Given this list of marker genes Ndc80, Tuba3a, Plk4, Ppp2r5d, Tubb4b, Ppp2r5e (protein phosphatase 2, regulatory subunit B', epsilon), Tuba1b, Ppp2r5a, Clip1, Cenpt, Smc4, Cep41, Csnk2a1, Hsp90aa1, Stag1, Kif2c, Ppp2r1a, Tubg2, Cdca5, Tuba4a, Nedd1, Csnk2b (casein kinase 2, beta polypeptide), Cdca8, Ccnb1, Cenpc1, Tubb6, Pds5b, Tubgcp2, Ska2, Itgb3bp, Nek2, Stag2, Mapre1, Pds5a, Cep70, Kntc1, Tuba8, Cenpl, Tubal3, Cep192, Bub1b (BUB1B, mitotic checkpoint serine/threonine kinase), Cenpf, Cenpo, Cep43, Tubb2b (NCBI Gene Id 73710), Seh1l, Bub1, Smc3, Ssna1 (NCBI Gene Id 98824), Sgo2a, Ppp2ca, Xpo1, Cep152, Wapl, Ckap5, Nup133, Cetn2, Rps27, Cenpq, Ofd1, Ska1, Cep250, Rad21, Mis12, Ahctf1, Tubb2a, Tubg1, Kif2a, Mzt1, Aurkb, Tuba1a, Dync1i1, Dctn2, Dync1li2, Pcm1, Zwint, Mad1l1, Dynll2, Zwilch, Ncapd2, Tuba3b, Cenpe, Akap9, Cenps, Tubgcp4, Cenpa, Rps27rt, Odf2, Bub3, Dctn3, Clasp2, Smc1a (NCBI Gene Id 80490), Spdl1, Taok1, Nuf2, Ppp2cb, Prkaca, Csnk1d, Haus5, Cdk1, Ninl, Firrm, Cenpk, Alms1, Smc2, Nup37, Tubb4a, Dync1h1 (dynein cytoplasmic 1 heavy chain 1), Haus8, Nup107, Eml4, Nup43 (nucleoporin 43), Cenpm, Cenpu, Ndel1, Zw10, Sdccag8, Spc25, Actr1a, Nde1, Kif2b, Nup98 (NCBI Gene Id 330609), Cdc20, Ppp1cc, Cenpn (centromere protein N), Cep164, Ywhae, Tubgcp5, Tubgcp6, Ppp2r1b, Mad2l1, Nudc, Tubgcp3, Haus4, Cep72, Csnk2a2, Haus1, Ppp2r5c, Tubb3, Cep63 (centrosomal protein 63), Nsl1, Incenp (NCBI Gene Id 98139), Ccp110, Cenpi, Ywhag, Clasp1, Ccnb2 (cyclin B2), Ranbp2, Dync1li1, Cenph, Cdk5rap2, Rangap1, Pafah1b1, Ncaph, Cep78, Numa1, Dctn1, Sgo1, Tubb1, Mzt2, Dynll1, Cep290, Rcc2, Cep135, Cenpj, Spc24, Csnk1e, Pmf1, Dsn1, Kif18a, Hdac8, Ncapg, Haus3, Haus6 (HAUS augmin-like complex, subunit 6), Nup85, Haus7 (HAUS augmin-like complex, subunit 7), Sfi1, Nme7, Nup160, Cep131, Tuba1c, Ercc6l, Cep76, Sec13, B9d2, Cep57, Dync1i2, Cenpp, Tubb5, Haus2, Plk1, Ppp2r5b, here is a description of the gene set: Mitotic Prometaphase Mouse Gene Set: REACTOME_MITOTIC_PROMETAPHASE studied in species Mus musculus